The following is a description of a gene set: species: Mus musculus Any process that stops, prevents, or reduces the frequency, rate or extent of muscle contraction. Mouse Gene Set: GOBP_NEGATIVE_REGULATION_OF_MUSCLE_CONTRACTION, and this is the list of marker genes: Pde5a (NCBI Gene Id 242202), Prkg1, Adcy10, Adra2a, Atp2a1, Irag1, Atp1a2, Gucy1a1, Bin1, Ptgs2, Grk2, Ptger4, Calcrl, Zc3h12a, Arg2, Stub1, Rgs2, Dock5, Kcnma1, Sri, Adora2b, Adra2c, Adrb2, Sod1, Adrb1, Tnnt1, Dock4, Arhgap42, Calca, Dbn1